Given this list of marker genes EOMES (eomesodermin), AS3MT, LSMEM1, ZKSCAN8, SRSF6, GARRE1, BCAM, SLC44A5, SKA1, GIT2, FAM107A, ADGRL1, RHO, WNK3, WSB2, REL, CNTFR, BBS10, ARL17A, TAS2R14, JMJD6, ADAMTS2, SSRP1, JPH1, CCL28, PLAG1, TRIM23, RORA, PATE4, IKBKB, MST1L, FOXJ3, DCUN1D5, HYCC1, TNS3, BAG1, NFE2L2, INVS, NPY2R, ARIH1, TRPC4AP, RPRD1A, ATAD2B, OSBPL10, ASPA, FGB, SWT1, FOXN3, TEF, GSK3B, GPM6A, CTNNBIP1, GON4L, RAP1B, NDOR1, EN2, TMEM260, NOVA2, RPTN, DKK3, here is a description of the gene set: Human Gene Set: MIR3139 studied in species Homo sapiens from publication Chen Y, Wang X (PMID 31504780) Genes predicted to be targets of miRBase v22 microRNA hsa-miR-3139 in miRDB v6.0 with MirTarget v4 prediction scores > 80 (high confidence targets).